The following is a description of a gene set: species: Homo sapiens Genes predicted to be targets of miRBase v22 microRNA hsa-miR-4460 in miRDB v6.0 with MirTarget v4 prediction scores > 80 (high confidence targets). from publication Chen Y, Wang X (PMID 31504780) Human Gene Set: MIR4460, and this is the list of marker genes: ZNF800, TVP23B, ARL15, ZBTB20, GPR161, DLST (dihydrolipoamide S-succinyltransferase), RIC1, CHCHD3, MMD, SULF2, MROH9, KLF9, ERC2, KBTBD6, PURB, ZKSCAN4, C6orf120, MED13 (NCBI Gene Id 9969), UBE2V1 (NCBI Gene Id 7335), IRGQ, ZBTB10, ABHD5, MFSD14A, FSTL4, CLDND1, MRPS18C, PARD6B, WDFY3, LHFPL2, HDGFL3, HDAC7, SUGCT, KATNBL1, NPR3, B4GAT1, ZNF781, TNFRSF21, PBOV1, ZC3H11A (NCBI Gene Id 9877), AFTPH, FCHO2, SRGAP3, PTBP3, NLK, WNK4, NFE2L2, TSPAN12, C6orf47, ACSL6, DYNLT3, CBLL1, CXADR, PALM2AKAP2, TANC2, BACH1, TSSK2, SEPTIN2, RALA, KAT2B, HEY2, SEL1L, ADAM10, IGFBP5, SYT1, IPO7 (NCBI Gene Id 10527), NMD3, TVP23C, CTNNA3, TMEM260, YOD1, KRR1, WASF1, SORCS1, BLTP1, EGR2, CCNB1, ANKRD17, MIER3, KLF6 (NCBI Gene Id 8025), SDC2, CD226, CCNE2, DYNC1LI2, RNF19A